The following is a description of a gene set: Defective CHST6 causes MCDC1 Human Gene Set: REACTOME_DEFECTIVE_CHST6_CAUSES_MCDC1 species: Homo sapiens, and this is the list of marker genes: CHST6, LUM, KERA, OMD, OGN, FMOD, ACAN, PRELP